The following is a description of a gene set: Mouse Gene Set: WP_COMPLEMENT_ACTIVATION_CLASSICAL_PATHWAY studied in species Mus musculus Complement activation, classical pathway, and this is the list of marker genes: C8a, Hc, C1ra (complement component 1, r subcomponent A), C1qc, C9, C2, C1s1, C7, C4a, C4b, C1qa, C8b, C1qb, C3, Cd55, C6, Masp1